The following is a description of a gene set: Abnormality of lipoprotein cholesterol concentration An abnormal increase or decrease in the level of lipoprotein cholesterol in the blood. Human Gene Set: HP_ABNORMALITY_OF_LIPOPROTEIN_CHOLESTEROL_CONCENTRATION studied in species Homo sapiens, and this is the list of marker genes: CCDC115, BBS7, CREB3L3, TTC8, BBS5, LDLR, APOA1, SAR1B, IFT172, PWRN1, UBR1, BBS10, PCSK9 (NCBI Gene Id 50983), LDLRAP1, IFT74, IFT27, SYNE2, MKS1, NPAP1, GPR101, BBIP1, FHL1, MKKS, CEP19, LPL, SYNE1, BBS12, PPP1R17, CFAP418, SMPD1, NPHP1, LIPA, ABCG5, APOA2, CYP7A1, LIPC, ALG6, TMEM199, ABCA2, EMD, FDFT1, BBS9, GBA1, APOA5, BBS2, APOE, SDCCAG8, GALNT2, CEP290, AIP, SCLT1, APOB, GHR, LMNA, BBS1 (NCBI Gene Id 79702), PCYT1A, PSMB8, TTPA, BBS4, GPIHBP1, LZTFL1, LRP6, SLC7A7, WDPCP, TRIM32, MAGEL2, ALB, ANGPTL3, CETP, DYRK1B, PPARG, MSMO1, SCAPER (S-phase cyclin A associated protein in the ER), PLAAT3, SCARB2, TMEM43, ABCA1, SNORD116-1, HERC2, SLC25A13, ARL6, EPHX2, MKRN3, APOC3 (apolipoprotein C3), PWAR1, ALMS1, SNORD115-1, ABCG8, MTTP, LCAT, NGLY1, APOC2, B4GALT1, CELA2A